The following is a description of a gene set: studied in species Homo sapiens Human Gene Set: GOBP_PHOSPHATIDYLINOSITOL_3_PHOSPHATE_BIOSYNTHETIC_PROCESS The chemical reactions and pathways resulting in the formation of phosphatidylinositol-3-phosphate, a phosphatidylinositol monophosphate carrying the phosphate group at the 3-position., and this is the list of marker genes: PIKFYVE, PIK3C2G, FIG4, PIK3C2A, INPP4B, SYNJ1, PIK3C3, INPP4A, OCRL, PIK3CB, PIK3CD, PIK3R3, UVRAG, PIK3R4, BECN1, PTPRQ, PIK3CA, INPP5E, ATM, PIK3CG, PIK3C2B, ATG14, SYNJ2